Given this list of marker genes Lef1, Hspd1, Bcl2l1, Plk2, Fgfr2, Flt3l, Pth, here is a description of the gene set: species: Mus musculus Mouse Gene Set: GOBP_APOPTOTIC_PROCESS_IN_BONE_MARROW_CELL The apoptotic process in cells in the bone marrow.